The following is a description of a gene set: from publication Chen Y, Wang X (PMID 31504780) Genes predicted to be targets of miRBase v22 microRNA mmu_miR_7664_3p in miRDB v6.0 with MirTarget v4 prediction scores > 80 (high confidence targets). studied in species Mus musculus Mouse Gene Set: MIR_7664_3P, and this is the list of marker genes: Sh3kbp1, Gemin5, Anpep, Zfp934 (zinc finger protein 934), Taf4, Lrfn5, Xiap, Stxbp3, Tmem116, Ppp2r2b, Lta, Dnajc12, Lmna, Sdk1, Snta1, Prdm8, Tmem25, Il7r, Lix1l, Cacnb2, Drp2, Sema6d, Fgd4, Ube2o, Slc8a3 (NCBI Gene Id 20543), Ppp4r2, Pmpcb, Hagh, Sh3bp5, Six2, Faf1, Insr, Tbl1xr1, Tmod3 (tropomodulin 3), Zfp566, Nufip2, Snx1, Ubqln2, Tpm1, Pate9, Slc44a2, H2bw2, Cdkl2, Cbln1, Cutal, Hltf, Egr3, Rab3c, Lsamp, Ehf, Rap1b, Med23, Ric3, Purb, Zfp518a, Plcxd2, Tanc2, Cyp2j13, Cradd, Ube3d, Nipal1, Megf9, Eps8l1, Ttr, Fez2, Axin2, Snrpb, Agap1, Tdrd3, Hycc2, Esrrg, Fam174b (family with sequence similarity 174, member B), Adamts6, Rrp12, Myo1c, Ino80c (NCBI Gene Id 225280), Col2a1 (collagen, type II, alpha 1), Fut9, Mal (myelin and lymphocyte protein, T cell differentiation protein)